The following is a description of a gene set: Despite high-affinity multimeric interaction between EPHs and ephrins (EFNs), the cellular response to EPH-EFN engagement is usually repulsion between the two cells and signal termination. These repulsive responses induce an EPH receptor-expressing cell to retract from an ephrin-expressing cell after establishing initial contact. The repulsive responses mediated by EPH receptors in the growth cone at the leading edge of extending axons and in axonal collateral branches contribute to the formation of selective neuronal connections. It is unclear how high affinity trans-cellular interactions between EPHs and ephrins are broken to convert adhesion into repulsion. Two possible mechanisms have been proposed for the repulsion of EPH-EFN bearing cells: the first one involves regulated cleavage of ephrin ligands or EPH receptors by transmembrane proteases following cell-cell contact, while the second one is rapid endocytosis of whole EPH:EFN complexes during the retraction of the interacting cells or neuronal growth cones (Egea & Klein 2007, Janes et al. 2005). RAC also plays an essential role during growth cone collapse by promoting actin polymerization that drives membrane internalization by endocytosis. part of: EPH-Ephrin signaling Reactome Pathway: EPH-ephrin mediated repulsion of cells studied in species Homo sapiens, and this is the list of marker genes: EPHA7, AP2A2, APH1A, EPHA8, PSEN2, PSENEN, EPHA4, EPHA6, EPHA3, AP2B1, EPHA5, EPHB2, VAV3, PSEN1, TIAM1, YES1, EPHB4, EFNA2, EFNB2, EFNA3 (ephrin A3), EPHB3, EFNA5, CLTB, APH1B, RAC1, EPHA1, ACTG1, AP2S1, EPHA2, CLTCL1, EFNB1, VAV2 (vav guanine nucleotide exchange factor 2), NCSTN (NCBI Gene Id 57297), EPHA10, SRC, EFNB3, CLTC, ADAM10, ACTB, EPHB6, FYN, EFNA4, DNM1, LYN, EPHB1, AP2A1, MMP9, CLTA, AP2M1, MMP2, EFNA1